The following is a description of a gene set: Human Gene Set: GOCC_CUL4A_RING_E3_UBIQUITIN_LIGASE_COMPLEX A ubiquitin ligase complex in which a cullin from the Cul4A subfamily and a RING domain protein form the catalytic core; substrate specificity is conferred by an adaptor protein. species: Homo sapiens, and this is the list of marker genes: DET1, GLMN, CUL4B, DTL, COP1, DDB1, CUL4A, TRPC4AP, RBX1, DDB2, ARIH1, CRBN, ERCC8, CDKN1B